The following is a description of a gene set: Human Gene Set: HP_CRANIAL_ASYMMETRY Asymmetry of the bones of the skull. Cranial asymmetry species: Homo sapiens, and this is the list of marker genes: AKT3, MTOR, PTCH1, MAF, PIK3CA, HRAS, CTBP1, NRAS, NSD2, CPLX1, PEX19, POLR3A, LETM1, FGFRL1, RNF135, KRAS